The following is a description of a gene set: studied in species Mus musculus The process in which the anatomical structures of the skeleton are generated and organized. Mouse Gene Set: GOBP_SKELETAL_SYSTEM_MORPHOGENESIS, and this is the list of marker genes: Hspg2, Hoxb8, Axin2, Smpd3, Satb2, Cyp27b1, Alpl, Actn3 (actinin alpha 3), Hhip, Fgfr3, Hoxd3, Runx2, Hoxb9 (homeobox B9), Nipbl, Col11a2, Twist2, Nle1, Neurog1 (NCBI Gene Id 18014), Slc39a1, Rara, Hoxc11, Eya1, Sfrp1, Osr2, Hoxb5, Trip11, Insig1, Chsy1, Eif4a3l1, Hyal2, Tiparp, Lhx1, Nab2, Sh3pxd2b, Serpinh1, Mmp2, Prkra, Schip1, Prrx1, Fgfr2, Tgfb1, Flvcr1, Ltbp3, Tifab (NCBI Gene Id 212937), Ripply1, Bmp4, Cst5, Pthlh, Asxl2, Tgfbr1, Hoxd4, Ppargc1b, Col13a1, Wnt9b, Cdx1, Myc, Stc1, Pcgf2, Bmp6, Grem1, Cited2, Zfand5, Hoxc8, Cer1, Hoxb4, Tmem119, Smad2, Col10a1, Ext2, Phospho1 (phosphatase, orphan 1), Hoxb2, Pax1, Nkx3-2, Pappa2, Hoxd11, Prrx2, Sox9, Pdgfrb, Hyal1 (hyaluronoglucosaminidase 1), Mmp13, Sp5, Col11a1, Mapk14, Irx5, Mef2d, Sik3, Tgfb2, Ift140, Hoxd10, Nodal (nodal growth differentiation factor), Eif4a3l2, Wwox, Hoxa2, Foxc1 (forkhead box C1), Vegfa, Osr1, Hoxb3, Zeb1, Ext1, Csgalnact1, Barx2, Carm1, Hoxa4, Dlx5, Ankrd11, Megf8, P2rx7, Hoxb6 (NCBI Gene Id 15414), Ndst1 (N-deacetylase/N-sulfotransferase (heparan glucosaminyl) 1), Nppc, Wnt10b, Twist1, Hoxa5, Recql4, Med12, Zfp950, Tbx1, Col27a1, Rarg, Lama5, Rab33b, Fosl2, Mef2c, 2610005L07Rik, Fgf8 (NCBI Gene Id 14179), Mycn, Men1, Plekha1, Dhrs3, Smad3, Sox11, Thbs3, Sox5, Fbn2, Enpp1, Shox2, Hottip, Tbx15 (NCBI Gene Id 21384), Hoxa7, Sfrp4, Scube2, Atg9a, Hoxa1 (homeobox A1), Hoxa3, Dspp (dentin sialophosphoprotein), Pax5, Frem1, Gas1, Grhl2, Npr2, Bmi1, Rdh10, Gnas, Acan, Fgf18, Fgr, Pds5a, Slc39a3, Mthfd1l, Hoxd9, Rab23, Acp5, Ryk, Ctnnb1, Idua, Six2, Thra, Spef2, Dlg1, Axin1, Foxn3, Gli3, Sgpl1, Ihh, Tcf15, Mmp14, Six4, Pex7, Wnt7a, Bmp7, Poc1a, Dync2i1, Hoxc9, Eif4a3, Msx2, Alx4, Zfp640, Vdr, Atf2, Tfap2a, Rflnb (refilin B), Col2a1, Tulp3, Col3a1, Sox6, Cbs, Thbs1, Wdr19, Nab1, Rarb, Ski, Mmp16, Mdfi, Galnt3, Acvr2b, Matn1 (matrilin 1, cartilage matrix protein), Chad, Nog, Myf5, Insig2, Col9a1, Ripply2, Tmem107, Por, Has2, Atg9b, Lrp5, Msx1, Pdgfra, Glg1, Ltf, Bpnt2, Nfix, Hoxb7, Hoxa11, Wnt9a, Tgfb3, Alx1, Setd2 (SET domain containing 2, NCBI Gene Id 70927), Rflna, Bmpr1b, Wdr48, Uncx, Tbx4, Pkd1, Gsc, Hoxd8, Six1, Fgf6, T, Alx3, Sulf1, Fuz, Ccn2, Trpv4, Dscaml1, Tgfbr2 (transforming growth factor, beta receptor II), Hoxb1, Psen1, Hoxa9, Comp, Col1a1, Dlx1as, Arid5b (AT-rich interaction domain 5B), Inppl1 (inositol polyphosphate phosphatase-like 1), Ift80, Fmn1, Bmpr2, Otor, Dlx2, Zmpste24, Lrp6, Csrnp1, Ifitm5, Ror2, Scx, Fgf4, Foxc2, Chst11, Cyp26b1, Hoxc4